Given this list of marker genes H4C5, SATB2 (SATB homeobox 2), ASXL1, ZFX, CDC42BPB, FGFR3, TERT, MOG (myelin oligodendrocyte glycoprotein), RAB11B, POGZ, EDN1, TNNT1, TRPV4, PCGF2, HRAS, NDN, GRB10, CNBP, MYO9A, CA2, GUSB, ATN1, PLCB4, NGLY1, NOTCH3, CRELD1, CACNA1C, DVL1, FBXO28, CHAMP1, GRHL3, CTSK, SLC5A7, GNAI3, SLC25A1, CACNA2D1, RNH1, SLC18A3, ARCN1, HNRNPC, EXOC2, DDB1, BICD2, UBB, PRKAR1B, SH3BP2, SIM1, OCA2, EP300, ZMYM2 (zinc finger MYM-type containing 2), GNPTAB, RECQL4, SYT2, SNRPN, IDS, MCM3AP, ADRA2A, DMD, AHDC1, AGRN, DPH5, LRPPRC, ZNF462, CAPRIN1, NFIX, VAMP1, NONO, CHAT, COL13A1, CREBBP, DNA2, GRIN1 (NCBI Gene Id 2902), ACBD6, MAGEL2, SKI (SKI proto-oncogene), TGFBR1, NALCN, UNC80, IDUA, PRR12, CCDC47, FXR1, PIGT, SNAP25, BMP2, NACC1, here is a description of the gene set: Obstructive Sleep Apnea is a condition characterized by the obstruction of the airway and pauses in breathing during sleep, which occur multiple times throughout the night. It is related to the relaxation of muscle tone that typically happens during sleep, leading to a partial collapse of the soft tissues in the airway and causing airflow obstruction. Obstructive sleep apnea studied in species Homo sapiens Human Gene Set: HP_OBSTRUCTIVE_SLEEP_APNEA